The following is a description of a gene set: We employed a proteomic strategy developed to characterize the in-vivo ECM composition of normal tissues and tumors using enrichment of protein extracts for ECM components and subsequent analysis by mass spectrometry. We grew subcutaneous tumors by injection into NOD/SCID/IL2R? mice of A375 human melanoma cells (poorly metastatic) or their highly metastatic derivatives MA2. The tumors were dissected 5 weeks later, and the tumor ECM was enriched and analyzed using mass spectrometry. We define the tumor ECM as the ensemble of ECM proteins and ECM-associated proteins found in two independent samples. A challenging question when studying the tumor microenvironment is to understand the origin of the tumor ECM; that is, whether the tumor ECM is produced and secreted by the tumor cells themselves, by the stromal cells or by both compartments. To address this question, we pursued the analysis of the melanoma xenografts described above, by identifying the origin of each protein. In order to be able to identify without ambiguity the origin of each protein, we required that proteins needed to be detected in two independent samples with at least two species-specific peptides in one of them. Using this strategy, we identified for each tumor type a set of matrisome proteins exclusively secreted by the (human) tumor cells, and another set exclusively secreted by the (murine) stromal cells. This gene set lists the matrisome proteins (based on the criteria mentioned above) secreted by the tumor cells in MA2 tumors and not in A375 tumors. Tumor-cell-derived matrisome proteins exclusively detected in highly metastatic melanoma human-to-mouse xenografts (A375_MA2) in comparison to poorly metastatic melanoma human-to-mouse xenografts (A375). Human Gene Set: NABA_MATRISOME_HIGHLY_METASTATIC_MELANOMA_TUMOR_CELL_DERIVED from publication Naba A, Clauser KR, Hoersch S, Liu H, Carr SA, Hynes RO (PMID 22159717) studied in species Homo sapiens, and this is the list of marker genes: LAMB2, COL11A2, COL10A1, COL8A2, SERPINE2, HMCN1, CSPG4, COL8A1, PXDN, HAPLN1, LOXL4, EMILIN3